The following is a description of a gene set: The function that stimulates a cell to grow or proliferate. Most growth factors have other actions besides the induction of cell growth or proliferation. Mouse Gene Set: GOMF_GROWTH_FACTOR_ACTIVITY studied in species Mus musculus, and this is the list of marker genes: Kitl, Klk1b4, Gkn1 (gastrokine 1), Hbegf, Bmp2, Fgf18, Nenf, Ambn, Ptn, Pdgfb, Ntf5, Bdnf, Fgf13, Tgfb2, Tgfb1, Fgf1, Mstn, Inha, Gpi1, Inhbe, Ccn2, Hdgfl3, Bmp1, Mia, Il9, Il11 (NCBI Gene Id 16156), Epgn, Igf1, Bmp6, Efemp1, Tgfa, Clec11a, Vegfd, Igf2 (insulin-like growth factor 2), Gfer (NCBI Gene Id 11692, growth factor, augmenter of liver regeneration), Fgf7, Cntf, Bmp7, Fgf11, Inhba (NCBI Gene Id 16323), Timp1, Ogn, Bmp8b, Hdgf, Thbs4, Vegfc, Fgf12, Bmp5, Mdk, Bmp8a, Il6, Tgfb3, Pspn, Nrg4, Fgf23, Pdgfc, Nrg2, Rabep1, Hgf, Il5, Bmp4, Fgf22, Cripto, Cd320, Jag2, Artn, Nrg3, Rabep2, Lif, Gmfg, Gdf10, Il12a, Il4, Prl2c2, Fgf9, Lefty2, Inhbb, Csf2, Gdnf, Fgf4, Pgf, Vegfa, Fgf5, Fgf8, Il7, Fgf21, Bmp15, Nodal, Gdf7, Csf1, Il3, Ccn3, Fgf16, Nrg1, Pdgfd, Il2, Fgf14, Gdf3, Osgin1, Nrtn, Fgf20, Gdf9, Fbrs, Prl2c3, Gdf11, Amh, Fgf15, Ereg, Klk1b3, Osm (NCBI Gene Id 18413), Gdf6, Amelx, Vegfb, Angptl3, Gdf2, Hspe1-rs1, Areg, Ntf3, Csf3, Osgin2, Fgf17, Prok1, Fgf2, Fgf10, Btc, Lefty1 (NCBI Gene Id 98355), Ccn5, Ccn6, Cdnf, Il12b, Gmfb, Pdgfa, Cxcl1, Cxcl12, Egf, Fgf6, Inhbc, Gdf5, Ngf, Fgf3, Manf (mesencephalic astrocyte-derived neurotrophic factor), Gh, Bmp3, Gdf15, Il34, Tff1, Gdf1, Vgf, Reg1, Bmp10